Given this list of marker genes Slc16a1, Slc16a7, Slc5a12, Slc16a3, Myc, Acacb, Slc16a8, Slc5a8, Emb, here is a description of the gene set: The directed movement of lactate into, out of or within a cell, or between cells, by means of some agent such as a transporter or pore. Lactate is 2-hydroxypropanoate, CH3-CHOH-COOH; L(+)-lactate is formed by anaerobic glycolysis in animal tissues, and DL-lactate is found in sour milk, molasses and certain fruit juices. Mouse Gene Set: GOBP_LACTATE_TRANSPORT studied in species Mus musculus